The following is a description of a gene set: Human Gene Set: HP_BICORONAL_SYNOSTOSIS Synostosis affecting the right and the left coronal suture. Bicoronal synostosis studied in species Homo sapiens, and this is the list of marker genes: FGFR2, AHDC1, SMO, ZIC1, MSX2, TCF12, FGFR1 (fibroblast growth factor receptor 1), RECQL4, H4C9, SCUBE3, ERF